The following is a description of a gene set: species: Mus musculus The chemical reactions and pathways involving dATP, deoxyadenosine triphosphate (2'-deoxyadenosine 5'-triphosphate). Mouse Gene Set: GOBP_DATP_METABOLIC_PROCESS, and this is the list of marker genes: Samhd1, Ak3, Guk1, Ada, Oga, Adk, Ak2 (NCBI Gene Id 52171)